Given this list of marker genes Sytl3, Sytl1, Nlgn2, Sdcbp, Sytl5, Nlgn3, Clstn3, Cpe, Cask, Nlgn4l, Dlg4, Sytl2, Nlgn1, Lrrtm2, Sytl4, here is a description of the gene set: Binding to a neurexin, a synaptic cell surface protein related to latrotoxin receptor, laminin and agrin. Neurexins act as cell recognition molecules at nerve terminals. Mouse Gene Set: GOMF_NEUREXIN_FAMILY_PROTEIN_BINDING species: Mus musculus